Given this list of marker genes BIRC5, PTPN6, SHC1, FLNA, MAPK14, CHUK, CEBPB, STAT3, PTPN11 (NCBI Gene Id 84990), MAPK1, ELK1, STAT5B, IKBKB, NFKB1, IL2RG, CBL, DOK2, JAK2, NFKBIA, PIK3R1, GAB2, MAPK11, INPP5D, MAPK3, PIK3CA, STAT5A, JAK3, RPS6KB1, BAD (NCBI Gene Id 572), GRB2, FOS, CEBPA, GATA3, IL4, SOCS3, TYK2, ATF2, AKT1, SOCS1, HRH1, RELA, FES, PIK3CD (phosphatidylinositol-4,5-bisphosphate 3-kinase catalytic subunit delta), IRS1, IRS2, SOCS5, SOS1, NFIL3, IL4R, PIK3R2, JAK1, STAT1, EP300, STAT6, here is a description of the gene set: IL4 signaling Human Gene Set: WP_IL4_SIGNALING studied in species Homo sapiens